Given this list of marker genes ZBTB14, CDK4, RRP9, RDM1, CREBZF, WRN, REEP4, CLIC4, CHRAC1, CDCA4, DR1, MYBL1, SHMT2, ARHGEF39, NAA15, CDCA8, DDX12B, ZNF367, PMF1, LIN52, FKBPL, C19orf48P, TK1, NUP153 (NCBI Gene Id 9972), PIGA, PSMC3IP, OIP5, UBE2C, DNMT3B, LBR, EXO1, H3C10, PHTF2, ERI1, H2BC9, SLC29A1, KNSTRN, RPA2, LCORL, ANP32E, RNF2, PBX3, BUB1B, FN3KRP, SLC3A2, IFRD2, CUL3, AP2B1, HMGN2, CEP20, ZNF207, KDM1A, HNRNPU, BAZ1B, POLE, ZNF680, NIPBL, CENPK, TIPIN, PBK, XRCC3, GINS1, MED30, PIGW, DARS2, H2BC6, LIN54, NUP62, NUDCD2, PRIMPOL, MCM3, RAD23A, ARL13B, LSM4, SLF2, RHEB, CENPE, TOPBP1, USP39 (ubiquitin specific peptidase 39), MAT2A, STK17B, HMGB3, CKS2, ALG10, BORA, ASPM, H2AC20, SLC25A40, PLSCR1, OBI1, SLC25A19, GINS3, SAE1, TACC3, FANCG, RFC2, ARID2, CLN6, NUF2, KPNB1, CCDC15, NT5C3A (5'-nucleotidase, cytosolic IIIA), POP7, TBC1D31, NCAPH2, KIF23, FIGN, MKI67, GAS2L3, HASPIN, TRA2B, AEN, FANCD2, DCAF1, FAR1, ZNF587, DBF4, RAD51AP1, CDKN2D, GART, C5orf24, HMGB1, CCNE1, CEP55, CDC20, RBBP4, CKAP2L, ARHGAP19, WDHD1, KNTC1, H2AC11, SMARCC1, NUP54, HNRNPD, CLSPN, CCSAP, ZMYM1, RMND1, CENPN, ORC2, POC1A, FKBP7, H2BC4, CDK1, STAT1, TOR1AIP1, GPR180, FNBP4, H1-3, E2F7, THRAP3, CENPL, H3C2, SNRNP25, PDS5B, H2BC7, USP37, ARHGAP11B, MYC, TNPO3, HNRNPR, MXD3, FZR1, TONSL, PPP3R1 (NCBI Gene Id 5534), FANCL (FA complementation group L), GTPBP2, PLK1, KIF18A, HNRNPA1, H2AC16, TCERG1, MCM4, SLFN11, MAGOHB, NSMCE4A, LMNB1, KIF2C, PASK, LCMT2, H4C9, ATF2, RAD51B, ZNF714, POLR1F, ACD (NCBI Gene Id 82538), GRK6, PYCR3, POLA2, CDKN2AIPNL, H2AC14, NUFIP2, KPNA3, TCP1, FKBP5, NUP35, TFDP1 (NCBI Gene Id 7027), DCK, AGPAT5, NOTCH2, HSPA9, KHK, RFT1, H2AC13, TCTN2, RPL22L1, CAD, TOP1, TUBB, NDC1, NUP98, MYADM, SENP1, CENPU, SSBP2 (NCBI Gene Id 51492), NUP88, DHX15, GNL3, RPIA, NUP85, ARHGAP11A, NEDD1, DOLPP1, CEP57L1, CDC42EP4, MCM7, ORC3, MTRFR, TRIM59, CDKN2C, HADH, CENPF, TCEA1, GGH, USP1, STMN1, DEPDC1, VPS26C, CDKAL1, SFPQ, MSH6, ATAD5, TEDC2, DCPS, PHF19, TICRR, SAAL1, CEP295, DHTKD1, ATAD2, PRIM2, ZNFX1, H3C4, BCS1L, TOMM40, MRPL17 (mitochondrial ribosomal protein L17), MTHFD1, UNG, EXOSC2, CDCA3, RNASEH2A, ORC1, INCENP, ALMS1, SNRPD1, ABHD2, NCAPG, L3MBTL2, BLM, C2orf69, PSRC1, H2AC25, UBE2D3, LDLR, SRSF10, ANKRA2, MYO19, CEP85 (NCBI Gene Id 64793), USP28, BRIP1, DZIP3, SEC14L1, KPNA2, AURKA, ZW10, DDIAS, NUCKS1, NSD2, ARRDC3, PARP2, HJURP, HEATR1, NTAQ1, NAP1L1, BCLAF1, UTP15, DSN1, CBX3, EXOSC5, MCM10, MDM1, CEP83, KNOP1, EME1, NCAPD2, MPHOSPH9, RPS6KA5, KATNA1, CASP2, RAD54B, PPAN-P2RY11, GPATCH4, CEP72, GPSM2, CENPM, NUP93, SF3B3, CWF19L1, TP53INP1, AFG2A, DUT, CBX5, SFR1, NOLC1, TAF1A (TATA-box binding protein associated factor, RNA polymerase I subunit A), CISD2, TTLL4, STIL, TUBG1, RPL39L, SNRPA, PRPF4, H2AC8, CDCA7L, SLC1A5, H1-2, KIF20B, CNTROB, KIF14, RBBP6, FIRRM, CDC25C, FUS, ZGRF1, KMT5A, SPC25, E2F1, ABHD10 (NCBI Gene Id 55347), FBXO4, NASP, ATP23 (NCBI Gene Id 91419), BMPR1A, SLC16A1, HMGXB4, KLHDC4, AHCTF1, PRKAA1, ZNF267, EIF4E, TMEM138, FAM83D, RTKN2, HELLS, ZNF684, SUV39H1, DNAJC9, TBRG4, METTL2B, NAPEPLD, NUSAP1, H2AC12, CEP152, H2BC13 (H2B clustered histone 13), SPAG5, DYRK1A, ARRB2, DDX20, MAD2L1, TTI1, DSCC1, RAD54L, ESCO2, LONP1, MRTO4, PKMYT1, HROB, CENPH, BCAR3, CDC25B (NCBI Gene Id 994), RAD51, H2BC14, C18orf54, FANCM, EXOSC9, TDP1, DEK, HAT1, MSH5-SAPCD1, H2AC4, GTPBP3, HAUS2, XRCC1, MARS1, DTYMK, POLR1E, MCM8, CCDC18, PALB2, MCM5, POLA1, DCLRE1C, EXOSC3, PGAP2, TTK, SMC5, ZNF530, PRC1, SKA3, SPATS2, CENPO, MNS1, NUP160, GPATCH11, OXNAD1, KIF4A (NCBI Gene Id 55595), STAG1, HSPE1, WDR46 (NCBI Gene Id 9277), IQGAP3, CDC6, SIN3A, ZNF518A, BARD1, ATF4, NCAPH, PPP3CB, POLR3K, TNPO2, H1-5, HNRNPAB, RECQL4, METTL16, NUP205, LRR1, FAM110A (family with sequence similarity 110 member A), CDCA7 (NCBI Gene Id 83879), HAUS6, SRSF3, PRIM1, CKLF (chemokine like factor), NUP50, HNRNPF, NOP58, MIS18A, E2F2, CFLAR, EFHC1, ZNF107, PCNA, RRM2, SMC4, HINT3, H3C13, ZNF138, GSTCD, CEP97, MDC1, PKNOX1, PAFAH1B3, DNMT1, HNRNPA2B1, IFIH1, EAF2, PFAS, BRIX1, PIMREG, TRAIP, EXOSC8, CKAP5, SLC1A4, C9orf40, NOC3L, PRR11, PTBP1, SKP2, TMX1, NET1, EZH2, KAT7, UACA, HMBS, BRCA2, WBP11, WDR76, GINS2, THEM4, PTGES3, KIF18B, PNN, MARCKS, ZNF146, HAUS5, RBL1, SLF1, AK2, CYP51A1, PIF1, PPIH, NUP107, THOC1, RNPS1, RNF26, ACACA, MRE11, GINS4, AHI1, RAPGEF6, MCM2, RAD1, HSPA8, CENPJ, C1orf174 (NCBI Gene Id 339448), HYLS1, EHBP1 (NCBI Gene Id 23301), WEE1, PLK4, MTFR2, FANCC, BUB3, TCOF1, CDK2, PCLAF, FANCA, KIF2A, RFC4, APOBEC3B, CSE1L, NEMP1, FANCE, GPR19, CHCHD3, ODF2, H3C3, ITGB3BP, JPT1, BRD8, MRPS18B, SRRM1, ZNF45, DDX46, NXT1, NCAPG2, RANGAP1, CCNF, LSM3, RFC3, SIVA1, RSRC1, POLD1, SEC22C, GMNN, PEX3, SASS6, TMEM209, NUP43, NFATC2IP, SP1, NUDT1, CCT5, H4C8, SGO2, HSPD1, IPO11, GARS1, DLEU1, CKS1B, SNRPB, ZNF100, NF2, RANBP1, CCNA2, H3C15, DDX10, HAUS7, CNOT1, H2AX, TROAP, PNRC2, DEPDC1B, CCDC34, CDCA2, C4orf46, CENPC, SP4, UCHL5, SKA1, HNRNPDL, E2F8 (E2F transcription factor 8), SMC2, LRRC45, RHNO1, CRYBG1, EBP, ESPL1, CCDC150, IFT25, UBE2R2, MIIP, DGCR8, BCL2L12, UTP4, POLD2, GRPEL2, ACTL6A, CENPQ, UBR7, AAAS, ZNF695, BRCA1, OARD1, HS2ST1, SS18, MIS18BP1, FBXL20, DIAPH3, WDR62, PPAT, DNA2, FBXO5, LDAH, ZNF551, IFRD1, THAP12, PAICS, BIRC6, TMPO, XRCC2, EWSR1, RAB8A, AARS1, HSP90AA1, JADE1 (NCBI Gene Id 79960), MIS12, PATL1, EIF3B, KHSRP (NCBI Gene Id 8570), RAD18, PKP4, DPYSL2, SUZ12, CKAP2, KCTD9, PCF11, UBE2S, INTS7, FAM161A, TEDC1, HAUS4, RAD21, TIMELESS, H4C5, CARHSP1, OPA1 (OPA1 mitochondrial dynamin like GTPase), GATAD2A, ZNF24, SPAG9, RUNX1, PMAIP1, AZIN1, RASSF1, H3C8, MYBL2, ZMYND19, CEP135, SLBP, HNRNPH3, CCNB2, EXOC4, TFAP4, MEIS2, BYSL, CENPA, H2AC17, TOB2 (transducer of ERBB2, 2), MZT1, CDC7, SMNDC1, UBE2T, NCBP1 (NCBI Gene Id 4686), TRIM45, ARL6IP6, CENPW, DTL, H2AZ1, TCF19, NPAT, EIF3A, ATF7IP, HAUS3, RACGAP1, SAP30, IFNAR1, LIN9, CEP57, ZNF473, TXNDC12, FAF1, RFC5, DHFR, TTF1, G2E3, NRGN, H3C7, ZWINT, ORC6, NCOA5, PTBP2, TRIP13, HIRIP3, ZNF92, RRM1, NUP58, TARS1, SMC3, CEP192, TOP2A, SNRNP40, FEN1, KIFC1, SHCBP1, PARPBP, ETV5, MSH3, RFC1, SPDL1, DDX21, R3HDM1, H4C3, HAUS1 (HAUS augmin like complex subunit 1), HACD2, PSIP1, PIGK, RBM8A, MACIR, DCLRE1B, HNRNPA3, GRWD1, TRIM37, CDR2 (cerebellar degeneration related protein 2), CACYBP, METTL4, GABPB2, ASF1B, SSRP1, PBRM1, ERCC6L, ANAPC1 (anaphase promoting complex subunit 1), CCNB1, USP53, RSBN1, SMC6, HAUS8, CAND1, MMS22L, FAM72D, MSH2, LYRM7, H2AC21, LRRCC1, INIP, LIAS, CHEK2, TMEM18, HMMR, CMC2, H4C4, CDCA5, SKA2, MND1, CDKN3, ZNF273, IQCB1, H2AC6, DCAF15, CWC27, NIF3L1, POU2F1, GGCT, EMG1, POLQ, MTF2, KIF24, CENPP, MAZ, ILF3, GABPB1, ARL6IP1, H4C13, FIGNL1, MCM6, FOXM1, BUB1, SYNCRIP, CHEK1, SLC38A1 (solute carrier family 38 member 1), KNL1, FANCB, COX20, FANCI, TUBA1C, SCLT1, ECT2, LAS1L, H2AC7, H4C1, POLE3, GPD2, FAAP24, AUNIP, DDX39A, EBAG9, RAD23B, NUDC, SRSF7, WDR4, KIF22, GTSE1, ING1 (inhibitor of growth family member 1), SUV39H2, NEK2, ZNF724, IFT80, RFWD3, DDX11, TAF5, ABCB10, MUTYH (NCBI Gene Id 4595), CHAF1A, KIF11, RAD9A, DCAF16, HCFC1, SRSF1, SMARCA5, DLGAP5, AFMID, SAPCD2, RTTN, MASTL, RAD51C, PPP1R10, NUP155, SUPT16H, DCLRE1A, GADD45A, ATAD3B, ABCE1, ZNF184, HLTF, SGO1, RIF1, CDT1, HDGF, POC5, CTDSPL2, TOE1, TOP3A, EIF2AK3, ELP5, RDX, HNRNPA0, NCAPD3, CCDC14, DCP2, BTG1, CIT, CEP78, FOXRED1, CIP2A, GEN1, RNASEH2B, YEATS4, KLHL23, CCHCR1, ZWILCH, PIM1, TMEM39B, H2AZ2, KIF15, FAM111A, HNRNPH1, RMI2, PCNT, MELK (NCBI Gene Id 9833), SMIM14, TEX30, TPX2, TTF2, CHTF18, ANLN, H2BC17, ZNF85, CMSS1, MRPL3, SLC25A36 (NCBI Gene Id 55186), AMD1, RNPC3, RMI1, PTTG1, HMGB2, LSM5, UHRF1, TMEM97, SMPD4, CASP8AP2, DBP, FAM76B, CNOT9 (NCBI Gene Id 9125), GPR137C, TUBD1 (tubulin delta 1), ACP1, CDK5RAP2, CCDC77, CENPS, NDC80, RCC1 (regulator of chromosome condensation 1), SPC24, ASXL1, H2AC15, FRAT2, MTBP, G3BP1 (G3BP stress granule assembly factor 1), GTF3C2, WRAP53, STIP1, CDC45, ATAD3A, JUND, POLD3, ZRANB3, H3C12, SRSF2, H2BC10, CDC25A, LNPK, TMEM109, DBF4B, AURKB, H2BC21, COQ7, TSEN15, BIRC5, KHDRBS1, CTCF, PRKDC, XRCC4, PGP, NEIL3 (nei like DNA glycosylase 3), SMCHD1, ANKRD17, KIF20A, VRK1, POLE2, BHLHE40, FAM111B, C5orf34, LARP7, SERTAD3, SMC1A, here is a description of the gene set: Genes bound and regulated by the DREAM complex according to multiple genome-wide datasets Human Gene Set: FISCHER_DREAM_TARGETS species: Homo sapiens Target genes of the DREAM complex. from publication Fischer M, Grossmann P, Padi M, DeCaprio JA (PMID 27280975)